The following is a description of a gene set: Human Gene Set: HP_VAGINAL_FISTULA The presence of a fistula of the vagina. species: Homo sapiens Vaginal fistula, and this is the list of marker genes: MNX1, TCTN3, POLR1B (NCBI Gene Id 88998), SPINT2, CAPN15, SALL1, RECQL4, SLC35A2, JAK3, POLR1C, DYNC2H1, FREM1, DYNC2I1 (dynein 2 intermediate chain 1), MKKS, IL10RB, IFT80, DYNC2I2, LONP1, WDR35, SALL4, KIF7, TCOF1 (NCBI Gene Id 6949), UBR1, POR, CCNQ, PI4KA, POLR1D, DACT1, DDB1, RNU12